The following is a description of a gene set: Human Gene Set: HP_SHORT_PROXIMAL_PHALANX_OF_FINGER studied in species Homo sapiens Short proximal phalanx of finger Congenital hypoplasia of one or more proximal phalanx of finger., and this is the list of marker genes: MTOR, GDF5, IHH, COL2A1, BMPR1B, KIF15, FGFR3